The following is a description of a gene set: Human Gene Set: GOBP_INTERMEMBRANE_LIPID_TRANSFER studied in species Homo sapiens The transport of lipids between membranes in which a lipid molecule is transported through an aqueous phase from the outer leaflet of a donor membrane to the outer leaflet of an acceptor membrane. This process does not require metabolic energy and can be either spontaneous or mediated by lipid transfer proteins (LTPs)., and this is the list of marker genes: PRELID1, SCP2, STARD7, PRELID3B, PITPNM1, PITPNC1, CPTP, PITPNM3, OSBPL8, PITPNA, PRELID3A (PRELI domain containing 3A), TMEM63B, PITPNB, OSBPL2, ESYT1, GLTPD2, MTTP, TNFAIP8L3, ATG2B, OSBPL5, C2CD2L (NCBI Gene Id 9854), CERT1, TTPA, PLTP, ATG2A, ABCA3, BLTP3B (bridge-like lipid transfer protein family member 3B), PLEKHA8P1, PLEKHA8, CIDEC, BLTP1, CIDEB, PITPNM2, PRELID2, TRIAP1, GLTP, CIDEA